Given this list of marker genes PTGS2, RBBP9, PTGER2, IL13, IL25, ARG1, CYP1A1, HPGDS, ITLN1, here is a description of the gene set: Any process that results in a change in state or activity of a cell or an organism (in terms of movement, secretion, enzyme production, gene expression, etc.) as a result of a stimulus from a nematode. Human Gene Set: GOBP_RESPONSE_TO_NEMATODE species: Homo sapiens